The following is a description of a gene set: species: Homo sapiens Human Gene Set: TRAVAGLINI_LUNG_CILIATED_CELL from publication Travaglini KJ, Nabhan AN, Penland L, Sinha R, Gillich A, Sit RV, Chang S, Conley SD, Mori Y, Seita J, Berry GJ, Shrager JB, Metzger RJ, Kuo CS, Neff N, Weissman IL, Quake SR, Krasnow MA (PMID 33208946), and this is the list of marker genes: HNRNPF, CFAP53, NUDT7, PRDX1, C20orf96, WWC1, TAT-AS1, HMGN3, BBS4, PRRT3, CD164L2, CIMIP6, PPP1CB, DNAI7, GSN, CRNDE, AMZ2, CFAP58, FABP6, SNTN, CCDC78, SPAG7, NHLRC4, CALM1, CEP290, PAPOLA, LRRC18, BICDL3P, ROPN1L, FAM161A, PTPRN2, IQCG, FDXR, ALDH3B1, TMEM59, SMYD2, TPPP3, CIMIP1, DNAI1, DZIP1, OAS2, CROCC, SMKR1, RAB28, FTH1, DTX3, TMEM67, TAX1BP1, SHROOM3, MICOS13, SLC22A23, STING1, GPX4, MYO1E, KIFAP3, SPAG17, CFAP20, STEAP3, TMEM190, RPGR, ABCA13, TP73, PKIG, MORN2, PPP4R3B, PSMD10 (proteasome 26S subunit, non-ATPase 10), CYP27A1, SPATA6, IFT70B, SNHG10, PSMD4, CCNA1, RIBC2, PNMA1, FAM227A, CCDC66, MYB, SLC44A4, LXN, BASP1, DNAJB13, CSPP1 (centrosome and spindle pole associated protein 1), METRN, NOP56, PZP, AGBL4, OR7E37P, KCNN3, EPPK1 (epiplakin 1), CFAP251, DNAI2, ALDH1A1, BIN3, IFT122, LYPLA2, TMEM232, RBM38, PLEKHS1, GLIPR2, LRGUK, DYDC2, C5orf15, LMO2, ZC2HC1C, S100A11, ENO4, RHPN2, CCDC184, FANK1, ERICH5, RARRES1, B9D1, LINC00467, DGKH, SLC27A2, DNAH11, FTO, C5AR1, ENKD1, IDH2, SCGB2A1, MED25, HSBP1, DNAH10, ENOSF1, CNDP2, DYNLL1, SYNE2, CYP4X1, CIPC, TP53TG1, PTGES3, ARHGAP39, IFT52, CCDC81, ADGB, SPATA18, DYDC1, TEKT2, CEP89, TEKT1, TRAF3IP1, MAP9, MRPL40, HADH, STX2, GBP3 (NCBI Gene Id 55271), ANXA11, WDR93 (NCBI Gene Id 56964), NSUN7, WLS, ERICH2, RNPEP, BCO2, TSPYL4, IK, EFCAB10, VDAC3, SMPD2, SLC35A2, MED31, PGM2L1, LZTFL1, SPAG8, GALC (galactosylceramidase), DTHD1, UBE3D, IFT56, C4orf3, SEMA3C, C11orf16, ASL, NDUFAB1, CD164, DTX2, IL7, SPMIP6, VWA3A, WDR35, DSTN, C12orf75, UGDH, PROM1, IGFBP5, PRR7, TSPAN1, DNAAF5, IFT25, BBIP1, TTC9, RBKS, TRNAU1AP, TMEM154, IFT172, ICA1L, SQLE, CCDC40, B9D2, SPATA6L, DNAH7, SPAG6, C10orf67, PPIE, VWA3B, CAPS, HAGH, CFAP36, GOLGA2P5, CLSTN1, MAP1B, ATP6AP1 (NCBI Gene Id 537), SLFN13, CDC42EP3 (NCBI Gene Id 10602), ORMDL2, ODAD1, VNN3P, CCDC88B, AKAP9, HMGB2, ZNHIT2, RPA3, MRPS31, LSM4, CCDC74B, CD24, CCNDBP1, TTLL5, CNTD1, MDM1, TTC39C, PIERCE2, ANXA4, KDM1B, ECRG4, CLIC6, KLHL6, DNAAF11 (NCBI Gene Id 23639), ENDOG, DNAJA1, ADGRE5, JOSD2, CIBAR2, CCDC148, RUVBL1, SPEF2, IFT27, C2orf81, ATP6V1D, PDK4, DSP, DAPP1, PHTF1, CACNG6, SPA17, DYNC2I2, ZNF106, PALMD (palmdelphin), CLMN, TTC5, MAOB, LRRC10B, DCDC2, IFT140 (NCBI Gene Id 9742), APH1B, ZNF688 (NCBI Gene Id 146542), LCA5, ELK3, CYGB, CLHC1, TUBGCP2, IRF2, NAT14, ARL4A, GABPB1-AS1, LINC01571, MS4A8, BCAS3, DNAJC10, SCPEP1 (NCBI Gene Id 59342), CLXN, ATP9A, RGS22, IFT74, DYNC2I1, THADA, DYNLT4, SRGAP3, LGALS1, GAS7, TBCB, IL20RA, PXN, TP53BP1, GLYR1 (NCBI Gene Id 84656), LRRC34, RSPH3, ENKUR, GOLM2, CHMP5, NDUFAF3, NUCB2, ANKUB1, CFAP95, PLEKHG7, FUZ, POLD3, SIX1, RABL2B, CST6, CLGN, SANBR, BAIAP3, TPST1, AHNAK2, MAGIX, TTC21B, GET1, MKS1, SIX4, KRT80, CDC16, CDHR4, IQCA1, DMKN, SPAG1, MIPEP, DNAH5, FHAD1, SOX2, TSPAN6, ECT2L, EPB41L4B, CFAP44, DRC12, PEX6, DYNLT2B, GSTA2, CFAP210, CCP110, EBNA1BP2, CCDC28A, DICER1-AS1, TTC8, COQ4, C22orf23, DZIP3, COQ10A, C6orf118, DCDC2B, CNIH2, CAPS2, PRR29, FSD1L, PLSCR1, CFAP263, CFAP96, AGR3, FANCF, SLC25A14, POLD2, ANKZF1, EFCAB12, SOD1, RSPH1, LRP11, CFAP52, KNDC1, HMGN2, SSBP3 (NCBI Gene Id 55126), EFHC1, MOK, RRAGD, CDKN2A, EFCAB2, ARMC9, GBP1, PSMB5, BPHL, DNPH1, TNFRSF19, RHPN1, GCLM, CEP126, POU2AF3, SEC14L3, SYTL2, MAILR (macrophage interferon regulatory lncRNA), PIH1D2, CERKL, TBC1D8, PFN2, CIR1, ADSS1, SLC22A4, BBS9, ZNF3, TMEM53, KIF21A, RUVBL2, TMEM231, ANKRD26, XPNPEP3, TCTN2, CBY1, CLUAP1, KRT42P, LRRC61, KATNB1, MCAT, CDC14A, RABL2A, STOML3, TTC21A, TUBA1A, NEK4, CMTM6, ANAPC5, CCN2, PRDX5, SLFN5, NAA20, SORBS2, KCTD12, PYCR2, CWH43, DEGS2, TULP3, MYEF2, BCAS1, CALM3, CABIN1, DNAAF8, WDR54, ODAD4 (NCBI Gene Id 83538), ATP6V0D1, ERGIC3, SIGIRR, PRUNE2, CSNK1G1, FOCAD, CFAP74, RPP38, IFI44L, CES4A, LDLRAD1, PCAT19, MRPL23, WDR90, AIG1, TUSC3, LRRC71, CFAP141, APOBEC4, CFAP90, SPATA4, ELF3 (NCBI Gene Id 2106), BAIAP2L1, DIXDC1, LMNTD1, ZMYND12, COBL (cordon-bleu WH2 repeat protein), BBS2, MARCKS, RIBC1, PLXNB1, DNAL1 (dynein axonemal light chain 1), PIGQ, NGRN, IQCK, CCDC82 (NCBI Gene Id 79780), FGF14, RRM2B, BHLHE41, ANAPC4, UFC1, CNTN5, BANF1, ESPN, CIMIP2C, MFSD10, KIF2A, CIMAP1B, HSPBP1, DNAH6, GPC3, CFAP43, EVI5, IQCD, HYDIN (HYDIN axonemal central pair apparatus protein), ICMT, NWD1, SPTBN1, ZNF204P, DNAI4, INTS10, ARMC3 (NCBI Gene Id 219681), RSPH9, CFAP276, PAIP2B, EPPIN, UBXN11, BCL2L1, RILPL2, RPA2 (replication protein A2), HIBADH, CCDC34, PPP1R16A, CHST9, DZIP1L, PIN1, HES2, CFAP61, IFT57, PIBF1, SRI, CTXN1, PLEKHB1, RTP4, CHMP2B, DNAAF6, VCF2, DNAJC16, MSRB1, PPIL6, NAP1L1, TCTN1, CRISPLD1, CD59, LMLN, ANKMY1, MTF1, STRBP, GLT8D1, CCDC17, ANG, DRC7, SERPINB6, H2AJ, MEIG1, NME7, UBAC1, STPG1, TUFM, TMEM14B, FLACC1, TRIM29, LITAF, MORN3, FAIM, EFHC2, SPATA17, PLCH1, DLEC1, LRRC45, GSTA1, CHCHD6, GSTP1, CCDC74A (coiled-coil domain containing 74A), MUC15, HHLA2, PDLIM4, CCDC69, CCDC181, ARL6, INHBB, ENAH, PAIP2 (NCBI Gene Id 51247), MNAT1, CFAP45, CSTPP1, LRRC26, HSD11B1L, IL5RA, ERICH3, PSMG3, SSB, CFAP70, CARS1, BBC3, MAP6, ECI2, PCSK1N, P4HTM, GSTA3, DNAJB6, FAM174A, BUD31, PFDN5, APBB1, ODF2L, DMD, CDC14B, CD4, FBXW9, DUSP4, NEK10, CCDC24, IGFBP7, UBXN10, DALRD3, USP51, B3GNT7, SRA1, OCEL1, CFAP144, KCNH3, CCDC138, USP2, LRWD1, CFAP57 (NCBI Gene Id 171012), STK33, DUSP18, CASC2, RPS4Y1, CES1, ITGB8, LRRC46, C1orf141, AK9, C11orf97, TSPAN3, YWHAH, MUC12, TEKT4, ARHGAP18, ABITRAM, NELL2, LRRC27, PGAP1, GOLGA2P7, CSTB, CFDP1, KLHDC9, GADD45A, AK8, MSH3, CYB5R1, PRRG4, CLDN1, CLDN8, CEP164, WARS1, TTLL10, GFOD2, SPATS2L, RAB36, CCDC39, STAM2, ARL13B, DENND6B, ZC2HC1A, AKAP14, LAMC2, KLHL32, INTU, AKR1C3, ANXA2, DPY30, PLIN3, PPP1R7, UNC93B1, TSTD1, CRLF1 (cytokine receptor like factor 1), C6orf52 (chromosome 6 open reading frame 52), ANKRD66, VSTM2L, WDR38, CCDC157, EFHB, SYS1, H2BC5, GIPR, LAP3, NUDC, IQCB1, TUBA4B, YBX3, SYT8, HAGHL, ARB2A, CAPSL, FAM81B (family with sequence similarity 81 member B), SPEF1, RNF32, PPME1, IQGAP2 (IQ motif containing GTPase activating protein 2), GAS8, TEX9, BBS5, TEKT3, SYTL3, CEP162, GNA14, PIERCE1 (NCBI Gene Id 138162), WDR19, MAPRE3, KIF19, SRD5A2, ZBED5-AS1, JKAMP, DYNC2H1, IFT88, ACYP1, SMIM19, GCC2, CCDC170, USP43, RSPH14, AKR7A2, TRAK1, SMIM5, HIPK1, TMEM107, BICC1, CCDC88C, RFX3, PLXNB2, SARAF, CFAP107, SHANK2 (NCBI Gene Id 654128), RIIAD1, CCDC80, SAXO4, FDFT1, DYNC2LI1, CEP19, EP300-AS1, ATXN7L3B, CCDC89 (NCBI Gene Id 220388), SGPL1, EFCAB6, SNX7, CHMP2A, RPGRIP1L, NEK11, GALK2, TMEM254, FBXO15, GNAI2, C6orf132, SSBP4, DNAH1, CEP43, ANKRD37, MORF4L2, PAPSS1, CFAP54, CLTA, DNAH3, FAM216B, FBXL13, TUSC2, IFT43, ZNF273, TMEM45B, DNER, VRK3, DDX3Y, CALM2, UCKL1-AS1, TMT1A, CDHR3, IFT81, CC2D2A, SMIM6, WDR73, TPRG1L, CTBP2 (NCBI Gene Id 87435), GAS2L2, GLB1L, THNSL2, APOO, CDKN1A, ENPP5, MPC2, RP1, PRPS1, KLHL13, SPON2, H1-2, ODAD2, TSNAXIP1, STK36, CNTRL, WDR13, IFT22, PIGT, CCDC146, SMAP2, ANKRD42, ANXA5, ZNF440, DZANK1, CFAP184, MAK, KIAA0232, CIB1, MAT2B, CCDC65, NRAV, SCAMP4, LRRC4, ABI2, OMA1, ST6GALNAC2, PLAC8, SPATA33, ANXA1, DRAM2, TTLL7, FOXJ1, OSBPL6, ABHD11 (NCBI Gene Id 83451), CDS1, MRPL41, MEAF6, B3GNT5, LCA5L, MGST3 (NCBI Gene Id 9272), POLR2I, MORN5, ANKRD45, DNAH9, EFHD2, SMIM22, KIF3A, MAPK10, SUDS3, COPRS, CIMAP3, DNTTIP1, DNAH2, NQO1, CEP83, ZNRD2, NEK1, LRRC23, AGTRAP, PPID, TMEM68, CENPBD2P, RSPH4A, STYXL1, MUC4, ZNF664, WDR86-AS1, LKAAEAR1 (LKAAEAR motif containing 1), DNAH12, POU2AF2, APPL2, DAW1, NME5, ALDH3A1, SYNE1, PCYT2, ANKRD65, GPX2 (NCBI Gene Id 2877), COL21A1, CCDC60, UBB (NCBI Gene Id 91253), DNAAF10, AKNA, DYNLRB1, TTC29, OXTR, EVA1C, P4HA2, GOLPH3L, PTPRT, CHST6, HACD4, WFDC6, LIMK2, COG7, LRRC56 (leucine rich repeat containing 56), SLC25A4, ODAD3, STOX1, CYB561 (NCBI Gene Id 1534), PIP, WDR49, IFT80, VPS35, CNPY3, DNAAF1, NICOL1, IGF2BP2, LRRC49, SLC16A5, MTSS2, FSTL1, PSENEN (NCBI Gene Id 94939), NCS1, ISCA2, C10orf95, HSPD1, TSGA10, ZMYND10, MPDZ, PSD3, ACAP1, CEP97, CRISP2, DNALI1, COA3, MDH1, PPP1R36, KIF27, SUGT1, SCARF2, PCM1, CCDC30, TUBB4B, SPAG16, IFTAP, CHCHD5, DOC2A, CSNK1G2, TRIP13, RFX2, FAM229B, THYN1, HOATZ, MAP3K19, POFUT2 (NCBI Gene Id 23275), ULK4, TMEM212, MAP1A, ODF2, MDH1B, HSPA8, MLF1, FAM47E, PRR13, C1orf87 (chromosome 1 open reading frame 87), LRRC74B, C8orf34, SAXO2, DYNLRB2, CFAP69, RRAGA, ZBBX, TP53INP1, ALOX15, CATIP, ORAI2, NANS, GLB1L2, XRRA1, IQUB, DYNLT5 (NCBI Gene Id 200132), USP11, PPOX, NT5C3A, C7orf57, AP3M2, CHIC2, SPATS1, CFAP46, CKB, C22orf15, TTC12, CETN2, IFT20, EFCAB11, PLTP, DNAJA4, CFAP221, GPR162, UNC119B, CFAP47 (NCBI Gene Id 652913), UCP2, HMGN5, ARL3, PPP1R14C, CENPM (NCBI Gene Id 79019), EZR, NAT1, TSPAN19, MGMT, GRIN3B, NSMCE1, NUDT14, FAM221A, CEP41, CRACDL, RHBDD2, CHURC1, LRRIQ1, OSBPL3 (oxysterol binding protein like 3), LRRC73, WFDC21P, CYSTM1, ETV6, AGR2 (anterior gradient 2, protein disulphide isomerase family member), LDLRAD4, TMEM121, C9orf72, TMEM138, XRCC1, MYG1, TTC16, C6, DNAI3, TJP3, CYTH2, RNF130 (ring finger protein 130), CLDN3, NPHP1, CDKN2D, DNAAF3, ZNHIT1, LEKR1, IFI6, RRAD, AK7, RUNDC1, PPP1R42, PRSS12, PLAAT3, TMEM218, HSP90AA1, NEK5, PACRG, KIAA2012, CATSPERD, IQCE, MARCHF10, SOAT1, C21orf58, DRC1, KCNE1, STOM, CDKL1, TMF1, KATNIP, PRR15, TMC4, KIF9, GALNS, TNFAIP8L1, CIMIP2B, SNW1, CTSL, RAMP1, ZDHHC1, FBXO36, SPATA7, NAA35, DPCD, RCAN3, LRTOMT, ETNK1, GLUL, AHSA1, CCDC33, BACE2, AZIN1, ANKRD54, ERICH6-AS1, ARMC2, IFT46, BAIAP2, KCNRG, SMIM14 (small integral membrane protein 14), AMPD3, SNX3, RALB, WRAP53, IQCH, SCCPDH, TMC5, OSCP1, CLDN16, LBH, SLCO3A1, CFAP91, CTSS, DYNLT1, MZF1, MORN1, KIF3B, PITPNM1, ALMS1, STMND1, HSPH1, DNAL4, SLC12A7, AZI2, SFXN3, MNS1, SYTL1, KATNAL2